Given this list of marker genes FAM3D, LSM1, TPPP, SSTR1, OR1D2, ACMSD, HOXA5, DEF8, PRSS33, DNAJC5, GTF3C1, SUPT20HL1 (SUPT20H like 1), ANKRD1, PRRX2, TMEM42, ZBTB7C, MYOF, RTL6, ETV3L, ARPP21, ADAMTS16, MIR183, NGB, UPP2, DUOX2, CLDN18, HYAL2, TLN1, PTH2 (parathyroid hormone 2), SPARCL1, NMBR, CHTF8, SCARF1, MAB21L3, RFX6, IL25, PLA2G2D, GPR180, TRIM42, BARX2, CAPN11, WWTR1, CLEC12A, NUDT11, LEFTY1, ADAM30, GLI1, RIC8B, CRTC3, POPDC3, IGLL1, C18orf32 (chromosome 18 open reading frame 32), MATN2, HEBP1, MOCS3, MYLK4, CYP7A1, CNTN3, BRPF1, DRC3, KLHL30, CTNNAL1, EPHA6, DEFB130A, RNF123, MFNG, KLK14, NPY2R, CACNA1F, MRAS, S100Z, HIPK4, ANK1, GCGR, GSTM2, KLHL40, MIR302D, ALPG, SKOR1, SFXN2, SEMA6D, ARFGEF2, CACNG5, HNRNPA0, SLC22A13, KHDRBS3, FBLL1, PMM2, FAIM2, SLAMF9, SLCO2B1, IGF1, MSRB2, BCL2L10, NHLRC4 (NCBI Gene Id 283948), PARP12, GRID2IP, RNF186, KRT16, SLC39A9, GATA6, CADM2, CDHR1, PRKAB1, NPW, XKR8, WAS, TNS4, RDH5, KRTAP5-3, SFN, CCKAR, SLC1A3, TGFBR3, KCNT2, HSF1, TOR3A, NUTM1, ODF4, OLFML2A, CRYGB, WFDC3, SLC39A3, PRRT3, DUSP29, EFHD1, SEC16B, IRGC, TIFA, PPP1R27, KIRREL3, MIR26B, GARIN1B, TMEM35A, SLC35A2, GNG8, here is a description of the gene set: Genes down-regulated in CD4 T cells from healthy donors: activated by anti-CD3 and anti-CD28 versus nitric oxide treatment. from publication Fernandez DR, Telarico T, Bonilla E, Li Q, Banerjee S, Middleton FA, Phillips PE, Crow MK, Oess S, Muller-Esterl W, Perl A (PMID 19201859) Human Gene Set: GSE13887_ACT_CD4_VS_NO_TREATED_CD4_TCELL_DN CD3-positive T cells were negatively isolated from 10 SLE patients and 9 healthy controls without SLE. All of the SLE samples and control samples were compared with one another to identify baseline differences in expression due to the disease. Next, T cell preparations from 4 of the control subjects were stimulated with either Nitric Oxide (NOC-18) 600 uM for 24hr or stimulated through CD3/CD28 for 24hr to determine which genes were responsive to these signaling mechanisms. Here, we show that activity of the mammalian target of rapamycin (mTOR), which is a sensor of the mitochondrial transmembrane potential, is increased in SLE T cells. Activation of mTOR was inducible by NO, a key trigger of MHP which in turn enhanced the expression of HRES-1/Rab4, a small GTPase that regulates recycling of surface receptors through early endosomes. Expression of HRES-1/Rab4 was increased in SLE T cells and, in accordance with its dominant impact on the endocytic recycling of CD4, it was inversely correlated with diminished CD4 expression. HRES-1/Rab4 over-expression was also inversely correlated with diminished TCRζ protein levels. Combined with follow up studies, these results suggest that activation of mTOR causes the loss of TCRζ in lupus T cells through HRES-1/Rab4-dependent lysosomal degradation. species: Homo sapiens